The following is a description of a gene set: electronically inferred by orthology from the curated human pathway This event has been computationally inferred from an event that has been demonstrated in another species.<p>The inference is based on the homology mapping from PANTHER. Briefly, reactions for which all involved PhysicalEntities (in input, output and catalyst) have a mapped orthologue/paralogue (for complexes at least 75% of components must have a mapping) are inferred to the other species. Reactome Pathway: Formation of the ternary complex, and subsequently, the 43S complex part of: Cap-dependent Translation Initiation species: Mus musculus, and this is the list of marker genes: Rps26, Rps28, Eif3d (eukaryotic translation initiation factor 3, subunit D), Rps24, Rps12, Eif2s3x, Eif3b, Rps8, Eif3f, Rps23, Rps27l, Rps7, Rps20, Rps18, Eif3k, Rps3a1, Rps4x, Rps13, Rps19, Rps17, Rps25, Rps10, Rps9, Eif3j2 (NCBI Gene Id 100042807), Eif1ax, Eif3i, Rps2, Eif3g, Rps5, Fau, Eif3e, Rps15, Rps11, Rps6